The following is a description of a gene set: species: Mus musculus Mouse Gene Set: REACTOME_COHESIN_LOADING_ONTO_CHROMATIN Cohesin Loading onto Chromatin, and this is the list of marker genes: Smc1a, Smc3, Pds5a, Rad21 (RAD21 cohesin complex component), Mau2, Pds5b, Stag1 (STAG1 cohesin complex component), Wapl, Stag2, Nipbl